The following is a description of a gene set: from publication Aujla SJ, Chan YR, Zheng M, Fei M, Askew DJ, Pociask DA, Reinhart TA, McAllister F, Edeal J, Gaus K, Husain S, Kreindler JL, Dubin PJ, Pilewski JM, Myerburg MM, Mason CA, Iwakura Y, Kolls JK (PMID 18264110) studied in species Homo sapiens Genes down-regulated in primary bronchial epithelial cells: control versus stimulated with IL17A. Human Gene Set: GSE10240_CTRL_VS_IL17_STIM_PRIMARY_BRONCHIAL_EPITHELIAL_CELLS_DN Primary HBE cells were stimulated with IL-22 and IL-17, and gene expression was studied using an Affymetrix platform microarray, in order to investigate which genes may be upregulated or downregulated in response to these cytokines. Of particular interest was the host defense genes such as antimicrobial peptides, which have been shown to be upregulated by IL-22 and IL-17 in skin keratinocytes., and this is the list of marker genes: F2R, GPAA1, PLD2, H1-0, XRCC6, SLC12A7, RGS12, SYMPK, C12orf71, SPRY1, ARPC4, TNFAIP3, CNPY3, IL4R, ADAMTS10 (NCBI Gene Id 81794), NEK8, ATP5F1E (ATP synthase F1 subunit epsilon), GNG2, GABBR1, MAFK, MRGBP, DOCK8, RABAC1, ARHGAP30, SERPINB9, TBC1D4, CAMK1D, IRF2, DEXI, NEFH, ERCC2, PLEKHG5, ARX, POLE3, IKZF1 (IKAROS family zinc finger 1), CASP2, ZNF688, MRNIP, ICAM2, HSD3B1, PBX4, PLEKHO2, RGP1, CPVL, ACIN1, RING1, PRDM14 (NCBI Gene Id 63978), PPIA, SLC7A4, REC8, EZR, AMIGO1, DUSP28, CTCF, PSMB7, ABCA1, ADGRG3, TMBIM6, FBXL6, DTNA, ADCY6, SLC35D2, P2RY10, ZCCHC24, SHANK3, LTC4S (leukotriene C4 synthase), JAG2, MOB2, RBM5, RAB4B, JAK1, RGS2, LGALS9B, PRRC2C, MIIP, CD72, TMUB1, MVK, SERPINF1, SNHG12, TWSG1, CORO7, STXBP4, MICALL2, INTS1, NLGN2, HSPA12B, ADRM1, AKT1 (NCBI Gene Id 207), RNF167, ALDH1L1, REX1BD, FAM83D, LPAR2, SSU72, TXN2, ITGA4, LINC00511, KLK8, AKAP8L, WIPI1, UBXN6, EPS8, PHLDA1, DHRS4, ICOS, ANKS1A, PDXP, ATP9A, FBXW4, NFATC2, CCL4, RPL38, PIM1, ASPSCR1 (NCBI Gene Id 79058), NFIC, TBC1D9, TRAPPC9, NCAPD2, MAD1L1, ADI1, AAAS, POLR2A, PPP4R3A, TBC1D17, BAIAP2, LAX1, CCNDBP1, SPATA33, GDI1, VIPR2, CALHM6, ZDHHC19, WRAP53, LPCAT2, XYLT2, BCKDK, GALT, RPH3AL, HMGA2, AGPAT2, SV2A, PIGS, ZNF280B, LAMB3, PHC1, PAQR5, KLHL36, ANO10, TGM2, OTUD5, RNF180, NUDT6, SP2, SELENOW, TYRP1, LPIN1, TBXAS1, DNAJB5, MACROD1, PGGHG, RAB11FIP1, PRKACB, FAM184B, FRG1, ALCAM, RNF123, LDLRAD4, IFNAR2, POLI, OTOA, MAP2K2, SSTR3, SLC35D3, SLC25A23, NR1H2, SKIC2, ADORA3, GABARAPL1, PPP1R18, ANKLE1, C11orf68, TOMM40, USP5, SSBP4, TIMM44, GGN, LIME1, FADS2, TRIOBP, GRAMD1A, WBP2 (NCBI Gene Id 96240), HCLS1, TTC19, ATP11B, AAGAB, EIF4A3, RRP9, NUP210